The following is a description of a gene set: Any of several heterotetrameric complexes that link clathrin (or another coat-forming molecule, as hypothesized for AP-3 and AP-4) to a membrane surface; they are found on coated pits and coated vesicles, and mediate sorting of cargo proteins into vesicles. Each AP complex contains two large (a beta and one of either an alpha, gamma, delta, or epsilon) subunits (110-130 kDa), a medium (mu) subunit (approximately 50 kDa), and a small (sigma) subunit (15-20 kDa). Human Gene Set: GOCC_AP_TYPE_MEMBRANE_COAT_ADAPTOR_COMPLEX studied in species Homo sapiens, and this is the list of marker genes: AP2B1, AP1M2, AP1G1, AP5S1, SYNRG, AP2M1, VPS39, AP3S2, AP5M1, VPS18, AP4E1, AP1G2, AP1B1, AP3M2, AP1S3, AP1S2, AP1S1, AP4M1, VPS33A, AP5Z1, TBC1D5, AP3D1, AP4S1, AP3B2, AP1M1, STON2, AP5B1, SLC18A3, SGIP1, AP3M1, AP2A2, STON1, AP2A1, AP3B1, AP4B1, VPS41, EPS15, AP3S1, AFTPH, CLBA1, AP2S1, BTBD8